The following is a description of a gene set: species: Homo sapiens Germinal centers (GCs) are clusters of activated B cells built on stromal cells known as follicular dendritic cells (FDCs). In the Peyer’s patches (PPs), GCs are chronically induced by bacteria and are the major sites for generation of gut IgA immune responses. Whether FDCs directly contribute to the IgA production in PP GCs is unknown. To investigate the role FDCs in gut immune system, we examined comprehensive gene profiles of FDCs purified from PPs or perypheral lymph nodes (pLNs) with or without immunization. We also tried to reconstitute the PP FDC signature in vitro by pulsed or continuous stimulation of pLN FDCs through TLRs, RARs or simultaneously through TLRs and RARs. Human Gene Set: GSE19401_PAM2CSK4_VS_RETINOIC_ACID_STIM_FOLLICULAR_DC_UP from publication Suzuki K, Maruya M, Kawamoto S, Sitnik K, Kitamura H, Agace WW, Fagarasan S (PMID 20643338) Genes up-regulated in the in vitro follicular dendritic cells from peripheral lymph nodes (96h): Pam2CSK4 versus tretinoin., and this is the list of marker genes: ST3GAL2, TOB2, ECT2, LUC7L3, MYBL1, IMPA2, OVOL2, HERC2P3, SLC17A1, PAPOLA, COPS5, NPM1, SLC43A1, CACNA2D3, SLC4A3, ELMO3, HES1, ANKRD55, WBP4, RACGAP1, FNDC11, SETD6, DUSP7 (dual specificity phosphatase 7), SLC39A6, CERS4, YTHDC2, ETV5, FGF7, MLF2, RAB29 (NCBI Gene Id 8934), RGS14, HMGCS1, GNL3L, RNF6, TMEM41B, XRCC2, ZNF410, TRIM8, GRK5, NDE1, ZNF573, WIPF1, OPHN1, KIF23, ARMT1, JUP, CENPI, UBE2E1, PANK3, TRAPPC2, C11orf58, ZNF248, GMCL1 (NCBI Gene Id 64395), PKD1P1, PCLO, GALR2, LBR, ZKSCAN5, ARGLU1, FAM184A, KLHL35, RPS23, ATM, MTMR6, RPS6KA5, ZNF154, KIR2DL4, ZNF264, PKD1P6, ABHD18, ARMC8, KIF15, ABCC5, HSD17B7, PTCD1, FBXO24, TRAPPC13, PPP2R5B, ADPRH, CTNND1, SAPCD1, STAT5A, ENTREP3, MTHFD2, RAD21, TRAFD1, PRR5L, NLGN4X, FRG1, TENT5C, NR5A2, ZNF430, IL21R, ADAMTS9, FRS2, CYRIB, SLC2A4RG, NDEL1, TNFAIP1, SRP9 (signal recognition particle 9), CCDC121, ETFDH, TNMD, RAD23B, RUNX1, IL18, TMEM140, FGG, PICALM, LMO2, APOBEC3C, KCTD13, PUM2, LRCH4, CCND1, CCDC59, OR1D2, PSAT1, PSTPIP2, EPB41, ZNF506, FGD1, CCDC69, IRF3, DYNC1I1, RXRG, HOXC6, MPHOSPH9, RASGRP2, C10orf95, SLC24A1, ACTL6A, RTN2, PCNA, TIMM10B, PIK3CD, KATNBL1, PEX11B, N6AMT1, PVR, LRIF1, SUMO2, OGFOD1, GTF2F2, IDH1 (isocitrate dehydrogenase (NADP(+)) 1), CFLAR, HMGB2, CAVIN1, FAM193B, HOXB7, CDC34, GNG10 (G protein subunit gamma 10), SLC44A1, PCLAF, RBM26, RRP15 (ribosomal RNA processing 15 homolog), ZNF329 (NCBI Gene Id 79673), RMDN1, FHOD1, CTNNB1, EFCAB2, SCTR, STEAP3, LPAL2, MMADHC, RMND1, ZDHHC18, CPPED1, MFSD11, ST7, FBXO22, OSBPL11, PAQR4 (progestin and adipoQ receptor family member 4), MPHOSPH8, SECISBP2, SLC13A3, FAM30A, TSPAN12, MINPP1, ADGRG1, LRP8, CYB5B, SORBS1, RCHY1, CHST2, CCL8, TDP2, RNF138, UBE2W, MAPKBP1, CSTF2T, PDLIM5, MRGBP, ZDHHC6, CSF2RB, DPY19L1, TOPBP1, PPM1A, TCP1, CTPS2